The following is a description of a gene set: species: Homo sapiens Elevated circulating alanine aminotransferase concentration An abnormally high concentration in the circulation of alanine aminotransferase (ALT). Human Gene Set: HP_ELEVATED_CIRCULATING_ALANINE_AMINOTRANSFERASE_CONCENTRATION, and this is the list of marker genes: MARS1, APOB, SEMA7A, CNOT1, TRMU, PEX14, TMEM199, TRMT10C, ATP7B, IFT56, XK, MPV17, MRPL3, NSMCE2, IARS1, DPYS, FADD, ATP6AP1, UQCRB, PIGL, TMEM165, LYRM4, SLC51B, VPS13A, ADK, TKFC, SMPD1, AHCY, PRKCD, PSMB9, MYO5B, HADHB, GALT, SLC22A5, POLD1, VPS50 (VPS50 subunit of EARP/GARPII complex), CYP7B1, NR1H4, STAT2, KIF12, HMGCR, ACOX2, DEF6 (DEF6 guanine nucleotide exchange factor), APOE, HMGCL, PEX2, SLC2A2, DOCK2, TWNK, HMOX1, SLC25A13, OTC, ALDOA, SCO1, TANGO2, PKHD1, VPS33B, HMGCS2, PGM1, USP53, GAA, POLG2, CPT1A, SLC37A4, NFS1, LMNA, SUCLG1, PCK1, COG7, EARS2, OCRL, BCAT2, MRPS2, CPT2, WRN, LIPA, DNAJC19, LYN, RRAGC, BAAT, UBR1, RRM1, MRPL44, SC5D